Given this list of marker genes Nrcam, Myoc, Spock1, Scn2b, Bin1, Ank3, Kcnq2, Bcan, Cntn2, Scn2a, Scn8a, Scn9a, Dag1, Nfasc, Iqschfp, Scn1b, Kcnq3, Hapln2, Scn1a, Sptbn4, Dlg1, Kcnk2, Cdh1, Kcnk4, here is a description of the gene set: Mouse Gene Set: GOCC_NODE_OF_RANVIER species: Mus musculus An axon part that is a gap in the myelin where voltage-gated sodium channels cluster and saltatory conduction is executed.